Given this list of marker genes RAB18, FSTL4, NXF1, PAN2, PGM2, WDR6, BEND6, CTNND1, GTF2IRD1, STARD13, FASTKD2, TRIM28, RACGAP1, SLC4A8, REV3L, TMTC3, KIF11, KDELR3, MEGF10, OCA2, FANCD2, NUP160, DPY30, PTPRS, SGIP1, GFM1, LRRC40, HDAC3, MKI67, MGAT5, IPO8, XPO5, L1CAM, ACAT1, GNE, VDAC2, PAPSS1, PARP1, FNTA, PCCB, KIF2C, BBS9, ANO10, BOP1, ZBTB22, IQGAP3, FBXL6, LTA4H, ABHD8, ANKFN1 (ankyrin repeat and fibronectin type III domain containing 1), TACC1, GUSB, NUF2, BICD2, ST3GAL1, CENPF, ATP13A2, PEG10, DOCK1, TRMT1, RAF1, WDR35, TSPAN12, SLC30A9, RALB, WEE1, IDH2, FEM1B, SPRED2, H2AZ2, POMGNT1, PPT2 (palmitoyl-protein thioesterase 2), MARS1, IMMT, SETX, ATP6V0A1, RNF26, PRODH, MYO7A, SKA2, RAD51, CEP170B, PTPA, NRF1, CDC42BPA, IPO13, ADSL, DLAT, PROKR1, RHBDF1, POC1B, SCRIB, HGSNAT, BRWD3, PLK1, BUB1B, STAM2, TJP2, GCDH (NCBI Gene Id 2639), MLPH, VGLL3, KLHL13, DUSP4, NAV1 (NCBI Gene Id 89796), SIGMAR1, DNMT1, EPHX1, PIK3R2, MED16, ADAM12, PLK4, PREX2, SHCBP1, HPS1 (HPS1 biogenesis of lysosomal organelles complex 3 subunit 1), VAT1, TRMT2A, CTBP2, CNTFR, IPO9, NNT, WWC1, MTCH1 (mitochondrial carrier 1), BLM, TAF2, POLR1B, CCNF, PBK, HROB (NCBI Gene Id 78995), RAB34, DDB1, SND1, KCTD5, DGCR8 (NCBI Gene Id 66034), MCM7, NOP2, RTTN, METAP2, CERS5, IVNS1ABP, CAD, COPS3, DARS2, AKT1, CERS4, TNS2, TMEM106B, PIK3R3, KNL1, RUSC2, ARL2BP, BCKDHB, ACAA2, CMAS, MBP, PHTF2, MICAL1, INTS7, ADAMTS5, PTBP2, KIRREL1, NADSYN1, PTPN14, DDX20, TTC7B, ITGB5, PLXND1, WDR36, TROAP, CCNB2, CD109, ANAPC5, KIF18B, SNU13, COPG1, SH3PXD2A, SCAMP1, DPP8, DLGAP5, L3MBTL2, ZMAT3, TRUB2, ATP5MC3, TIMP4, NOL6, MDH2, REEP4, NBEA, here is a description of the gene set: IgG cytoplasmic tail interferes with the induction of antigen-response genes species: Homo sapiens Genes up-regulated in B lymphocytes treated by anti-HEL and expressing BCR fusions with: IgM versus IgMG. Human Gene Set: GSE7218_IGM_VS_IGG_SIGNAL_THGOUGH_ANTIGEN_BCELL_UP from publication Horikawa K, Martin SW, Pogue SL, Silver K, Peng K, Takatsu K, Goodnow CC (PMID 17420266)